Given this list of marker genes ASL, SPINK1, GK, SLC37A4, PNPLA2, XPNPEP3, here is a description of the gene set: studied in species Homo sapiens Human Gene Set: HP_CHRONIC_PANCREATITIS A chronic form of pancreatitis. Chronic pancreatitis